The following is a description of a gene set: This event has been computationally inferred from an event that has been demonstrated in another species.<p>The inference is based on the homology mapping from PANTHER. Briefly, reactions for which all involved PhysicalEntities (in input, output and catalyst) have a mapped orthologue/paralogue (for complexes at least 75% of components must have a mapping) are inferred to the other species. studied in species Mus musculus electronically inferred by orthology from the curated human pathway part of: Nucleotide-like (purinergic) receptors Reactome Pathway: Adenosine P1 receptors, and this is the list of marker genes: Adora2a